The following is a description of a gene set: studied in species Homo sapiens Human Gene Set: GSE17721_CTRL_VS_PAM3CSK4_4H_BMDC_DN mouse primary BMDCs were stimulated with tlr ligands and gene expression changes were profiled on Affymetrix arrays Genes down-regulated in comparison of control dendritic cells (DC) at 4 h versus those stimulated with Pam3Csk4 (TLR1/2 agonist) at 4 h. from publication Amit I, Garber M, Chevrier N, Leite AP, Donner Y, Eisenhaure T, Guttman M, Grenier JK, Li W, Zuk O, Schubert LA, Birditt B, Shay T, Goren A, Zhang X, Smith Z, Deering R, McDonald RC, Cabili M, Bernstein BE, Rinn JL, Meissner A, Root DE, Hacohen N, Regev A (PMID 19729616), and this is the list of marker genes: IPO4, TMEM39A (NCBI Gene Id 55254), CHDH, CAV2, NDEL1, MTPN, FUS, FSCN1, PLG, RIN1, OSR1, BTF3L4, TBL1X, STXBP1, IGSF9, RAB10, ELL2, RPS6KA2 (ribosomal protein S6 kinase A2), PRRC2A, CYP51A1, NAMPT, ZNF264, APOA5, NDP, DNLZ, BMP5, KLF5, ANXA5, SQSTM1, ZC3H11A, CCN1, SNX16, DMTF1, COX17, NRL, UBXN4, NECAB3, CFLAR, UBL4B, CACNA1H, GYPC, HSPA1B, AHCTF1, GHRH, BHMT2, SCNN1B, HELQ, ADARB2, MYL1, MOB1A, PAFAH1B1, IQGAP1, MEF2A, C21orf91, MTMR7, SLC39A4, PDGFA, NET1, CCDC71L, FOXD3, TMA16, KRT1, MAFG (MAF bZIP transcription factor G), COL5A3, DTX2 (NCBI Gene Id 57652), IER5, PSMA6, MIA, CYSTM1, CMTR1, SNTB2, EIF2S2, GNA13, MTMR14, TTC39C, DUSP9 (NCBI Gene Id 1852), BLOC1S4, FRMD6, PARP14, CHRNA5, IFITM2, CLDND1, CCNL1, ZFAND3, EBI3, PLEKHA3, PEDS1, EPHA8, IFNAR2, SUPT5H, NEUROG2, CFHR1, FABP3, POP7, MTDH, PLEKHA5, CDCA3, DLGAP4, MYL9, DDA1, PPP1CB, MRPL52, NR5A2, ARPC5, SRSF6, RGS20, SUOX, FDPS, CD72, MAP3K12, PDHA2, MRPL54, SFSWAP, HERC2, CD209 (CD209 molecule), WBP4, PHTF2, FGF3, CYP27B1, BBLN, VCAN, TXN, HNRNPH3, TRMT10A, SOCS3, FCHO1, AHR, GLMP, UPP1, BHLHE41, FAM76A, NFKB1, UBE2S, SNTB1, WASF3, VTN, CCND2, KATNBL1, OLR1, NAPB (NCBI Gene Id 63908), COPS5 (COP9 signalosome subunit 5), USP47, SNCG, PLAGL2, IGSF6, ABCC8, CHIC2, STAT5A, PMM2 (NCBI Gene Id 5373), HP, CEMIP, ZNF865, GSTM1, HADHB, BCL9, SACM1L, KLF3, AKR1D1, PDZK1IP1, CCL1, CPA1, FAM107B, LMO4, TLE2, GRB14, CBLN1, GDE1, STARD4, GABRA3, KCNE1, PAH, CSN2, KCNA4 (NCBI Gene Id 3740), CORO2B, SIX4, BEX4, ANGPTL1, SRF, FLNB (filamin B), IL23A, DSCAML1, PTPN23, PMPCA, DPPA2, MKKS, ZNF112, KSR1, RNF6, DGAT2, WWC2 (WW and C2 domain containing 2), PDK4, PLAAT3, RNF41, ID2, IGSF8, ASB16, CITED2, WNT5A, SLC46A2